Given this list of marker genes Gm7290, Gm15542, Mrgpre, Nlrp6, Gm5905, Fadd, Gm19094, Tssc4, Gm45417, Gm16982, Polr2l, Tspan32, BC024386, Gm22019, Sct (secretin), Cracr2b, Gm39117, Ifitm1 (interferon induced transmembrane protein 1), Mir6404, Krtap5-3, Krtap5-25, Ctsd, Gm25416, LTO1, Gm25370, Th, Tnnt3, Krtap5-26, Gm5054, Taldo1, Gm20501, Fgf4, Gm2431, Mir7064, Mir3105, Ano9, Dusp8, Brsk2, Fgf15, Muc5b, Gm7514, Mir7063, Krtap5-20, Acte1, Syt8, Gm10013, E230032D23Rik, Sigirr, Phlda2, Ap2a2, Gm6471, Irf7, Nadsyn1, Pgghg, Fgf3, Tmem80, Gm4553, Gm9711, Mir3104, Phrf1, Ifitm10, Cd81, Tpcn2, Dhcr7, Rnh1, Gm45889, Sirt3, Cd151, Hras, Drd4, Psmd13, Mrgprf, Shank2, Gm10153, Cttn, Ccnd1, Cox8b, Tnfrsf26, Krtap5-5, Muc5ac, Gm15579, Snora52, Krtap5-22, Gm33148, Ano1, Osbpl5, Krtap5-1, Eps8l2, Nap1l4, Mrgprg, Ppfia1 (NCBI Gene Id 97413), Pkp3, Cdkn1c, B230206H07Rik, Muc2, Ins2 (NCBI Gene Id 16334), Mir483, Gm28821, Tnfrsf23, Gm14372, Trpm5, Cars1 (NCBI Gene Id 27267), Krtap5-2, Slc22a18, Krtap5-4, 4933417O13Rik, Gm32786, Gm10575, Ascl2, Gm26143, Chid1, Mir675, Rplp2, Mrgprd, Pnpla2, Tollip, Ifitm3, Lrrc56, Gm23297, Gm15580, B4galnt4, R74862, Gm34964, Mob2, Lsp1, Prr33, Krtap5-21, Rassf7, Lmntd2, Kcnq1ot1, Igf2os, Tspan4, Slc25a22, Bc1 (NCBI Gene Id 100568459), Faddos, Krtap5-24, Mrpl23, Ifitm5, Gm25725, Gm26793, H19, Smim38, Mir210, Kcnq1, Gm10152, Cdhr5, Gm4535, Gm45181, Ifitm6, Gm39119 (predicted gene, 39119), Ifitm2, Gatd1, Krtap5-23, Cend1, Nctc1, Deaf1, Tnni2, Igf2, Tnfrsf22, Pidd1, Ptdss2, here is a description of the gene set: studied in species Mus musculus Mouse Gene Set: chr7F5